Given this list of marker genes UGT1A3, UGT2B17, ABCB1, HSD11B1, CYP3A4, UGT2B7, SERPINA6, HSD11B2, AKR1C1, ALB, here is a description of the gene set: part of: Drug ADME species: Homo sapiens Prednisone (PREDN) is a prodrug of prednisolone (PREDL), and is rapidly absorbed. To achieve high uptake of the near water-insoluble molecule the highest dose 50 mg has to be dissolved in 250 ml water. Its conversion to the highly active prednisolone (PREDL) in liver cells is reversible but represents the favored reaction direction.<br>Prednisone and prednisolone are considered to be fully therapeutically equivalent. The theoretical advantage of avoiding high GI concentrations of prednisone by administering prednisolone directly has never been shown to be clinically relevant.<br>Only 2–5% of a given dose of prednisone is excreted unchanged in urine. After hydrogenation to prednisolone at least 20 metabolites and their conjugates are formed and excreted. The main metabolites both after systemic and topical use are 20alpha- and 20beta-dihydro-prednisone, as well as 20alpha- and 20beta-dihydro-prednisolone (20AH-PREDN, 20BH-PREDN, 20AH-PREDL, 20BH-PREDL), in addition to the 6beta-hydroxy compounds 6B-OH-PREDN and 6B-OH-PREDL. Hydrogenation of PREDN and dehydrogenation of PREDL are complementary reactions that are dominant in different cell types. While liver and fat cells convert PREDN to PREDL, colon and kidney cells partly convert PREDL back to PREDN. We have depicted this equilibrium by showing example reactions in hepatocytes and kidney cells in the diagram. Reactome Pathway: Prednisone ADME